Given this list of marker genes GGT1, here is a description of the gene set: To be excreted in urine, glutathione conjugates undergo several hydrolysis steps to form mercapturic acids which are readily excreted. The first step is the hydrolysis of a gamma-glutamyl residue from the conjugate catalysed by gamma-glutamyltransferases (GGTs). These are membrane-bound, heterodimeric enzymes composed of light and heavy peptide chains. Extracellular glutathione (GSH) or its conjugates can be hydrolysed to give cysteinylglycine (CG, or CG conjugates) and free glutamate (L-Glu). Hydrolysis of GSH provides cells with a local cysteine supply and contributes to intracellular GSH levels. Defects in GGT1 can cause glutathionuria (GLUTH; MIM:231950), an autosomal recessive disorder characterised by increased GSH concentration in the plasma and urine. Mutations that cause GLUTH can occur in both chains of the GGT1 dimer. species: Homo sapiens Reactome Pathway: Defective GGT1 causes GLUTH part of: Metabolic disorders of biological oxidation enzymes